Given this list of marker genes PIK3R2, CTNND1, CDH15, CTNNB1, CADM2, SDK2, SKAP2, CD151 (NCBI Gene Id 977), SRC, CLDN10, CLDN23, SPTBN1 (NCBI Gene Id 91654), CDH11, PLEC, CDH10, AMOT, CLDN7, LIMS2, CRB3, TYROBP, SIRPA, MAGI2, PTK2, NECTIN3, FBLIM1, ANGPTL4, PTPN11, CLDN16 (claudin 16), WASL, NCK2, NPHS2, PARD6G, CDH12, LIMS1, KRT14 (keratin 14), CDH1, JUP, SFTPA2, PARVA, CLDN20, SNAI1, TNRC6C, PRDM8, NPHS1, MOV10, CDH6, TNRC6A, ANG, COL17A1, FOXF1 (forkhead box F1), CLDN5, PXN, CADM1, CLDN18, CLDN3, ILF3, ITGB4, AFDN, SP1, PIK3CB, NCK1, CLDN14, CLDN22, CLDN11, DST, HEYL, KIRREL2, CLDN8, SOX10, PARVB, GRB2, CLDN15, HOXC8, MIR200C, TESK1, CTNNA1, PRKCI, FERMT2, PALS1, LAMB3, ADAM19, KIRREL1, CDH2, KRT5, PARD6B, FLNC (filamin C), CDH3, LAMC2, CLDN2, ACTB, ACTN4, CD2AP, SFTPA1, CDH24, LAMA3, SDK1, VASP, CLDN9, CLDN6, CD47, ACTN1, CDH19, NECTIN2, CADM3, FLNA, FYN, CDH5, ZC3H12A (zinc finger CCCH-type containing 12A), SIRPB1, ADAM33, CDH4, ILK, NECTIN4, AGO4, CLDN19, CDH13, AGO3, F11R, CLDN12, PIK3R1, CASK (NCBI Gene Id 8573), NECTIN1, PATJ, CLDN4, CDH18, ZEB2, SIRPG, SPTAN1, PARD6A, CDH9, CLDN1, CDH8, CDH17, BHLHE22, AGO1, FYB1, ACTG1, ITGA6, PTPN6, PARD3, PVR, RSU1, ACTN2, CDH7, KIRREL3, PIK3CA, IQGAP1, ACTN3, TNRC6B, AGO2, SFTPD, ARHGEF6, ITGB1, PTK2B, CLDN17, here is a description of the gene set: Cell-Cell communication Human Gene Set: REACTOME_CELL_CELL_COMMUNICATION species: Homo sapiens